Given this list of marker genes Sigirr, App, Peli3, Peli1, Peli2, Nlrp12 (NCBI Gene Id 381948), here is a description of the gene set: Any process that modulates the frequency, rate or extent of the Tl signaling pathway. Mouse Gene Set: GOBP_REGULATION_OF_TOLL_SIGNALING_PATHWAY species: Mus musculus